Given this list of marker genes PSME2P4 (NCBI Gene Id 338096), MIR4801, LINC02265, ENSG00000302423, KLF3, PTTG2, PABPC1P1, MIR574, TLR6 (toll like receptor 6), LIAS, KLF3-AS1, SMIM14-DT, PDS5A, LINC02513, TLR10, RFC1, RPL21P45, RNU6-32P, ZBTB12BP, ELOCP33, LINC02278, RNU6-887P, KLHL5, SMIM14, ENSG00000251642, RPL9, LINC02505, N4BP2, UGDH-AS1, RNA5SP160, RNU7-11P (RNA, U7 small nuclear 11 pseudogene), MRPS33P2, TLR1, UGDH, TMEM156, WDR19, KLB (klotho beta), RELL1, ARL4AP2, PGM2, RNA5SP159, ARAP2, UBE2K, TBC1D1, RNA5SP158, RNU6-836P, DTHD1, NSUN7, RNU7-74P, NWD2, MIR1255B1, RHOH, FAM114A1, RBM47, RNU6-1112P, RN7SL558P, ENSG00000293349, MIR4802, MIR5591, LINC02616 (NCBI Gene Id 101928721), ENSG00000287659, C4orf19, LINC01258, ENSG00000247193, RNU6-1195P, LINC01259, WDR5CP, CHRNA9, KRT18P25, here is a description of the gene set: Human Gene Set: chr4p14 studied in species Homo sapiens